The following is a description of a gene set: An abnormality of any of the muscles of the pharynx. Abnormal morphology of musculature of pharynx Human Gene Set: HP_ABNORMAL_MORPHOLOGY_OF_MUSCULATURE_OF_PHARYNX species: Homo sapiens, and this is the list of marker genes: LRP12, RILPL1, NOTCH2NLC, PLP1, GIPC1, MATR3